Given this list of marker genes ZNF542P, CDC37L1, HAUS1, LAMB3 (NCBI Gene Id 3914), MMP7, UBR3, KRT14, CX3CR1, KRT17, NR3C2, LINC02035 (long intergenic non-protein coding RNA 2035), TRIM29, IRX1, KRT15, GALNT3, PI15 (NCBI Gene Id 51050), CCL28, ACTG2, AK5, NTRK2, IL20RA, ZNF398, TM4SF18, PDK4, ISM1, CP, LONP2, ACTA2, CX3CL1, ITGA2, CYP4X1, OXTR, CITED1, SERPINA6, SORL1, FMO5, CGNL1, STC2, APLP2, FUT8-AS1, PAPOLA, RARRES1, DMD (NCBI Gene Id 548327), CNN1, MAOA, HIPK2, WLS, HNRNPLL, MYLK, GABRP, HYCC1, EHF, KCTD14, CYB5R2, CYP2J2, ERICH1, PERP, SYNM, KRT23, KRT6B, EFS (embryonal Fyn-associated substrate), MGP, PNMA8A, PTGER4, CA2, ITM2A, RIOK3, ID4, LYPD6, ENTPD5, SPATA17, DST, SAA1, SFRP1, TES, SOCS2, TTC6 (NCBI Gene Id 319089), MRPS25, CPB1 (NCBI Gene Id 1360), PIP, ELF5, AZGP1, HOOK1, CLIC6, PDZK1 (PDZ domain containing 1), MYBPC1, IL17RB (NCBI Gene Id 55540), KLF8, CDH1, KRT5, SNTB2, ATP11B, here is a description of the gene set: Human Gene Set: TURASHVILI_BREAST_LOBULAR_CARCINOMA_VS_DUCTAL_NORMAL_DN BACKGROUND: Invasive ductal and lobular carcinomas (IDC and ILC) are the most common histological types of breast cancer. Clinical follow-up data and metastatic patterns suggest that the development and progression of these tumors are different. The aim of our study was to identify gene expression profiles of IDC and ILC in relation to normal breast epithelial cells. METHODS: We examined 30 samples (normal ductal and lobular cells from 10 patients, IDC cells from 5 patients, ILC cells from 5 patients) microdissected from cryosections of ten mastectomy specimens from postmenopausal patients. Fifty nanograms of total RNA were amplified and labeled by PCR and in vitro transcription. Samples were analysed upon Affymetrix U133 Plus 2.0 Arrays. The expression of seven differentially expressed genes (CDH1, EMP1, DDR1, DVL1, KRT5, KRT6, KRT17) was verified by immunohistochemistry on tissue microarrays. Expression of ASPN mRNA was validated by in situ hybridization on frozen sections, and CTHRC1, ASPN and COL3A1 were tested by PCR. RESULTS: Using GCOS pairwise comparison algorithm and rank products we have identified 84 named genes common to ILC versus normal cell types, 74 named genes common to IDC versus normal cell types, 78 named genes differentially expressed between normal ductal and lobular cells, and 28 named genes between IDC and ILC. Genes distinguishing between IDC and ILC are involved in epithelial-mesenchymal transition, TGF-beta and Wnt signaling. These changes were present in both tumor types but appeared to be more prominent in ILC. Immunohistochemistry for several novel markers (EMP1, DVL1, DDR1) distinguished large sets of IDC from ILC. CONCLUSION: IDC and ILC can be differentiated both at the gene and protein levels. In this study we report two candidate genes, asporin (ASPN) and collagen triple helix repeat containing 1 (CTHRC1) which might be significant in breast carcinogenesis. Besides E-cadherin, the proteins validated on tissue microarrays (EMP1, DVL1, DDR1) may represent novel immunohistochemical markers helpful in distinguishing between IDC and ILC. Further studies with larger sets of patients are needed to verify the gene expression profiles of various histological types of breast cancer in order to determine molecular subclassifications, prognosis and the optimum treatment strategies. from publication Turashvili G, Bouchal J, Baumforth K, Wei W, Dziechciarkova M, Ehrmann J, Klein J, Fridman E, Skarda J, Srovnal J, Hajduch M, Murray P, Kolar Z (PMID 17389037) Genes down-regulated in lobular carcinoma vs normal ductal breast cells. studied in species Homo sapiens